Given this list of marker genes Pold3, Prim2, Rfc3, Pold1, Rpa2, Terf2, Rfc5, Pot1a, Wrap53, Rfc2, Dkc1, Pcna, Pold4, Ppp6r3, Acd, Lig1, Pola2, Stn1, Ctc1, Fen1, Terf1, Blm, Wrn, Nop10, Gar1, Rpa1, Nhp2, Ccna2, Cdk2, Pold2, Prim1, Dscc1, Rfc4, Pif1 (NCBI Gene Id 208084), Chtf18, Chtf8, Dna2, Rfc1, Pola1, Ankrd28, Rpa3, Rtel1, Terf2ip (telomeric repeat binding factor 2, interacting protein), Tert, Ccna1, Ppp6c, Ten1, Shq1, here is a description of the gene set: Mouse Gene Set: REACTOME_EXTENSION_OF_TELOMERES Extension of Telomeres studied in species Mus musculus